Given this list of marker genes DDAH2, PRODH, APBB1, HSPG2, MIR15B, CFDP1, MMP2, MIR133A1, PPP1CA, KCNIP3, UBE2B, CTSH, STAT5A, MAPK8IP2, FCER1G, ELMO2, BRAT1, CECR2, BNIPL, KAT5, ARHGDIA, JAG2, KRAS, AARS1, RBCK1, PTTG1IP, BCL2L14, NAIP, MIR29A, HMGB1, TMIGD1, SCG2, TOPAZ1, PRAMEF17, INS, LIG4, HYOU1, MBTD1, DNMT1, CASP2 (NCBI Gene Id 835), LRP5, CHST11, RNPS1, MRPS30, MIR27A, GATA1, SGK1, PHLDA2, RAPSN, SGK3, ING4, NUPR1, PML, FAM3B, PEG3, PDCD7, WNT11, RPS7, RPS3, SYCP2 (NCBI Gene Id 10388), SLK, G6PD, FZD9, YAP1, DRAM2 (DNA damage regulated autophagy modulator 2), SEMA6A, PLA2R1, CDK11B, HIPK3, TNFSF9, EPO, ALOX12, INPPL1, DLX1, NSG1, TAOK2, KLF4, KCNMA1, RASA1, GRID2, BRMS1, FAP (NCBI Gene Id 2191), SH3RF2, NODAL, STAT5B, RET, BCL11B, ID3, MIR29B1, PAX3, USP17L3, MDM2, IFIT3, ORMDL3, MIR182, CASP12, EYA2 (NCBI Gene Id 2139), DDRGK1, SP100, MAPK9, MAP3K11, ZNF443, SAP18, PRKCI, VDAC2, PRKCZ, MIRLET7F1, CHMP3, HSPD1, TIGAR, DNASE1, CX3CR1, TIAL1 (NCBI Gene Id 8430), VPS72, MYBBP1A, CRYAB, IER3IP1, HLA-G, NR4A3, ZSWIM2, BCL7C, DAXX, TCIRG1, BCL2L13, USP17L21, PAGE4, PDCL3, IL24, WWOX (NCBI Gene Id 9621), GRINA, CDKN1A, CTSB, PDPN, NME3, BABAM2, TXNDC5, AREL1, SOX8 (SRY-box transcription factor 8), RPS3A (ribosomal protein S3A), MIR361, EEF2K, RSL1D1, RARA, NOL3, TNFRSF19, IFT57 (NCBI Gene Id 55081), EP400, NME2 (NME/NM23 nucleoside diphosphate kinase 2), NUAK2, STAT1, ITCH, SEMA3E, CAPN3, NUGGC, ASCL1, SGMS1, SYCE3, DDIAS, BLCAP, WNT7A, ACTN3, RTKN, PTMA, FAIM, IL12B, CARD8, RASSF6, USP53, PPP1R13L, HINT2, IFNB1, TRAIP, THOC6, DNASE1L3 (NCBI Gene Id 1776), TNFAIP8L3, CXCR4, OGT, EBF4, INHBA, DMAP1, GADD45A, NET1, RPS6KB1, SPI1, STK26, PRDX3, PINK1, MERTK, TNFRSF10C, SMAD3 (NCBI Gene Id 51521), MFN2, MAP3K12, LTBR, NME1, PPP2R2B, CORO1A, CHEK2, CHEK1, MAP3K9, TM2D1, USP17L7, RBM5, EGR3, MAP2K5, TNFRSF11B, AGO4, MAPK1, LTF, WNT5A (Wnt family member 5A), UNC5B (NCBI Gene Id 23663), SMO, ATCAY, GRIN2A, TPT1P8, NAE1, PDE1A, RB1, BDKRB2, CEBPB, RNF183, PSMG2, SIN3A, NOG, KPNA1, NCK1, FYN, ING5, NFATC4, ATP13A2, BNIP3, RNF157, AVEN, PTGIS, SON, DNMT3A, GAL, CDCA7, MIR320A, ITGB2, CLEC7A, ARHGEF2, EMP2, CIB1, SHISA5, FGA (NCBI Gene Id 2243), HCK, HSPA1B, TIA1, PRAMEF10, CGB7 (NCBI Gene Id 95511), PAWR, TCF7L2, TNFAIP8L2, GPR65, FGF4, ACIN1, RRP1B, MELK (maternal embryonic leucine zipper kinase), MFSD8, RNF34, STK3, YARS1, STXBP1, CAAP1, SERPINB9, EIF2AK2, NIBAN2, FBH1, CLEC5A, TMEM117, ATOX1, IRF3, BCL10, FRZB, BRAF, DCC, EYA1 (NCBI Gene Id 2138), CDK11A, SOX2, BIK, PRAMEF4, ANGPT1 (NCBI Gene Id 284), CITED2, WNT10B, TFDP1, NCSTN, NEK6, AHI1, CARD11, IFIT2, FGF2, TNFRSF25, SYK, SUDS3, CD160, HRAS, PRKAA2, MAPKAP1, BCAP29, BIRC6, DUSP6, ESR1, BMPR1A, ATN1, TNFRSF1B, MAGEH1, TNFSF11, TRIM2, MNT, TGFB1, ITPKB, PTPA, PPM1K, NFE2L2, LGALS14, HELLS (helicase, lymphoid specific), ATOH1, NES, MAEL, PDE3A, SPG11, CASP8AP2, ERP29 (NCBI Gene Id 10961), IGF1, SAV1, NGFR, FGF10, DAPK2, DNM1L, CCNL1, AATF, CHIA, THOC1, CASP6, SLC39A10, HSPA5, STK40, WNT16, MIR30E, TNFRSF21, PAK2, MYOCD, VEGFA, VIL1 (NCBI Gene Id 7429), VPS54, TFAP2D, C8orf17, DAD1, MAGEA3, PTMS, BBC3, MIR23A, NPC1, CARD6, GADD45B, BIRC3, COMP, TOPORS, AKT1S1 (AKT1 substrate 1), NONO, OLFM1, HSPB2, PRDX5, OXR1, CHL1, ALK, ATAD3A, PCSK9, HSPA1A, CUL1, ELL3, TNFRSF12A, ALDH1A3, SST, TRADD, SH3RF1, EIF5A, LRP8, TNFRSF18, CUL4A, RIPK1, VHL, PPP1R13B, GRK5, DUX4, COA8, ARHGEF6, BCL2L15, PAX2, SPHK2, ATG5, POU4F1, DAPK1, DNASE2, RTL10, MIR138-1, MAP1S, TPT1, MAGEA4, LGALS2, HOXA5, DDX41, PRAMEF1, AIFM2 (AIF family member 2), ARMCX5-GPRASP2, IL4, APAF1, BMP4, FLNA, WNK3, TMEM161A, IL6, CRLF1, PRKD2, IFI6, POU4F2, ANXA2, TLR6, PDIA3 (protein disulfide isomerase family A member 3), JAK3 (Janus kinase 3), SIRT1, CD27, ZMAT3, CRYBA1, TNFRSF1A, EDNRB, PDE6B, YME1L1, PTK2B, HGF, P2RX7, ITGA1, PPARA, HIF1A, CIDEC, GSK3B, TGM2, ACTB, PRAMEF12, SMG9, IL13, VCP, CSRNP3, PIK3CB, HPN, ADARB1, FCGR2B, SIRT5, ACTC1, SOD2, IRF5, SFPQ, EVA1A, PLCG1, USP17L1, EYA3, GZMM, PRAMEF25, CCL3, LAMTOR5, PPARD, RACK1, HSP90AB1, TNFRSF10A, WNT1, NTRK3, CDIP1, RAMP2 (receptor activity modifying protein 2), TRAF4, NDNF, LTA, MNAT1, PRAMEF14, COL2A1, CD14, TSC22D1, NME2P1, NPM1, PHB1, PMAIP1, BMI1, SOX10, BAG6, PRKAA1, BCL2, NR4A1, CXCR2, MIR17HG, VDR, USP17L6P, PLA2G1B, CTLA4, RNF216, STAMBP, TP53BP2, BCL6 (BCL6 transcription repressor), MEF2D, F3, NSMF, VPS35, GRM4, CAST, PRAMEF19, LCN2, CDK5, TIFAB, STEAP3, CRH, ST20, RASSF5, TXNDC12, MFSD10, UNG, NOS1, PRKCH, MAG, TRAF1, GAS6, CD248, MECP2, RB1CC1, FOXC2, ADORA2A, DEPTOR, TMBIM6, NF1, PNMA5, HIP1R, SMAD5, UNC5A, GZMA, EGLN1, ASNS, PPM1F, RAG1, MEAF6, PPP1R10, CARD16, CSRNP2, ARHGEF7, EPG5, XPA, IFNG, MIR222, TARDBP, LPAR1, ST8SIA2, NLRP1, ALPK2, CSNK2A2, ZMYND11, USP17L8 (ubiquitin specific peptidase 17 like family member 8), CASP7, SORT1, ARHGAP10, NEURL1, STX4, PYCR1, MLLT11, SKP2, SOCS2, PTPN6, PLK1, ZEB2, LGALS7B, CD2AP, IKBKE, SPN, BBS10 (NCBI Gene Id 79738), POU3F4, CERS6, LRP6, COL6A2, PTCRA, MIR140, FLT3, KIF14, CASP14, SULF1, CAMK2D, GIMAP8, XKR4, UFM1, PRR5, COLEC11, ZFP36, CD40LG, GADD45G, RELA, ANGPTL4 (angiopoietin like 4), ANP32E, USP17L4, CLIP3 (NCBI Gene Id 25999), CYLD, POU3F3, PRKCD, PARL, MEF2C, SP1, NLRP2B, MIR1-1, DBNDD2, RAPGEF2, IL12A, RAD21, XKR7, COL6A1, IFI27, CEACAM5, CSNK2A1, NRP1, RORC, CIDEB, APP, MIR101-1, MIR675, FOXC1, PF4, SLC25A6, KATNB1, TAF6, TNFAIP8L1, PPP2CB, IL10, GULP1, APLP1, PAK6, SH3GLB1, FOXP1, ANO6, LYN, UBE2D3, ACTN4, ADIPOQ, DELE1, MIR15A, TP73, RPL10, PPT1, SH3KBP1, MIR142, LIMS2, PRKCE, FCHSD1, FOXO1, ELP6, SERPINE1, ITGB1, PIP5KL1, EBAG9, SNX6, SPDEF, SLFN12, HTT, DFFA, CBL, ABCC9, PTGS2, RYBP, CDKN2D, FIS1, CLU, BRCA2, MIF, PARP2, PKN1, GLS2, FBXO11, LYPD3, SCRIB, FBXO21, PLK2, DDX47, EMILIN2, CCL2, CAV1, ATF3, AGTR2, TMEM238L, TENT5B, TRAF3IP2, PRAP1, EPB41L3, CUL5, TJP1, CDK19, MIR221, PRDM11, ZC3H12A, GNGT1, MIR181B1, SEMA5A, INCA1, GPER1, SNW1, PAK5, ALOX15B (arachidonate 15-lipoxygenase type B), CITED1, TAX1BP1, IL11, SLIT2, E2F2, TNFSF14, AIFM1, DPP8, ARF6, MIR210, GRN (granulin precursor), FASTK (Fas activated serine/threonine kinase), ERBB4, UXT, RNF186, TFAP4, FAIM2, LONRF2, ZNF212 (zinc finger protein 212), ANGPT4, CCAR2, CAPN2, PFKFB3, RPS27L, DNM2, MTDH, MIR132, E2F1, FGF20, BACE1, RPS6, MED1, EGLN2, TMEM196, FANK1, SCN2A, BID, MYB, ERCC5, PDCD4, SOD1, KRT20, PRAMEF9, NR4A2, EMP1, CBX4, KCNJ8, BAD, MAPK8IP1, PA2G4, GGCT, GCLM, PDCD2L, CAPN10, SCRT2, GATA5, IFI27L1, TNIP2, ADAM8, SERPINB13, CCND2, DDR2, SFRP4, ERFE, UBQLN1, ATF6, HEY2, TSC22D3, SRA1, NME5, DAPK3, ANP32CP, CDC73, NHERF1, SEMA4D, HTR2A, ERCC6, MIR21, EN2, EIF2S1, P2RX1, PIM1, DDB1, NTRK2, MLST8, TNFSF15, MRPL41, APBB2, BCL2A1, LTK, SOCS3, METTL21C, TRAF7, TUBA1A, PALB2, GSTP1, PRR7, FEM1B, GOLPH3, ADAR, MRGBP, ADNP, STUB1, DAP3, NCK2, B4GALT1, TLR3, PIAS1 (protein inhibitor of activated STAT 1), DAB2, SCX, API5, ATP2A2, RNF130 (NCBI Gene Id 55819), SIX4, USP17L2, GLI3, AHR, UNC13B, BARD1, PACS2, MAPK3, MMP9, RPS6KA1, MCM2, IRF7, SHC1, TPX2, CCNL2, ZC3H8, HSP90AA1, PPIA, PAX8, NANOS3, FATE1, EEF1E1, PTEN, ZPR1, TCIM, QARS1, BLOC1S2, HIF3A, CIT, ATP5IF1, ISL1, ITGB3BP, PEA15, SUPV3L1, ZBTB7A, FBXO10, ERCC3, IL1A, ADCY10, ST3GAL1, PDPK1, C1QBP, CD274, LAPTM5, HTRA1, S100A8, SLC9A1, DUSP1, DIDO1, MIR495, DIPK2A, XKR9, EPC1, MNDA, ADRA1A, TERT, TNFSF18, LGALS3, PYCARD (PYD and CARD domain containing), TLE5, OPA1, EEF1A2, THEM4, STK24, IGFBP3, MTFP1, BIRC7, PCDHGC5, MAP2K7, ARL6IP5, NPR2, FAS, AXIN1, MIR98, ITGA5, BNIP2, ATG4D (autophagy related 4D cysteine peptidase), PTGFR, ANXA1, EGFR, LGALS12, IFNA2, USP17L11, EPC2, GPI, USP27X, CEACAM6, UNC5C, FAF1, MAP2K1, C1D, CCR5, APC, MIR375, SGPL1, KCNQ3, KRT8, TMC8, GRIK2, RALB, TP53AIP1, MIR186, NPY5R, RBM25, TBX1, HDAC2, STK4, DKK1, THRA, CD2, CD44, FFAR4, MEF2A, HNF1B, CNTFR, FRS2, CYP1B1, HINT1, DKKL1, PMP22, CTNNBL1, PERP, FZD5, KDM2B, MCL1, PRAMEF27, DPF1, SNCB, IL6R, DHRS2, NCKAP1L, MAP2K6, TNFAIP3, EXOG, PRAMEF33 (NCBI Gene Id 645399), MINAR2, CRIP1, NKX2-5, ARAF, AIFM3, DLG5, MIR30B, FZD1, BUB1, VTCN1, DNASE2B, IL17A, CXCL10, MINDY3 (NCBI Gene Id 80013), IGF2R, NOTCH1, BLID, XKR6, RYR2, GFRAL, MPV17L, TNFSF10, TLE1, NOD1, ITGA4, GBE1, CHI3L1, EDA2R, TMBIM1, FHL2 (four and a half LIM domains 2), PHLPP1, ACSL5, APEX1, ITGAV, USP28, PPARG, DLC1, AKTIP (AKT interacting protein), RAF1, PPP2R1B, ACTN2, TGFB2 (NCBI Gene Id 7042), LCK, PCGF2, SHC4, RNF41, BMPR1B, UTP11, EIF2AK3 (eukaryotic translation initiation factor 2 alpha kinase 3), NR1H4, CCR7, AURKB, NAIF1, BTG2, SMAD6, BCL2L1 (NCBI Gene Id 598), TMEM219, MIR20A, TMEM14A, CDK5R1, CASP1, BMP5, G2E3, ARMC10 (NCBI Gene Id 83787), PIK3CD, SHB, NUDT2, JADE1, EI24, HTATIP2, MX1, ROBO2, FCMR, MGMT, MAPK7, SNCA, UBD, ARG2, RGL2, CCL5, ACVR1C, IL20RA (interleukin 20 receptor subunit alpha), LOX, ENSG00000274276, AFP, ANXA4, BCLAF1, SRGN, ATP2A1, GZMH, ZFP36L1, C8orf44-SGK3, CREB3L1, HTR2B, AAMDC, SPHK1, HDAC1, BAG1, BEX2, HDAC3, E2F3, USP17L12 (NCBI Gene Id 100287205), BMX, CALR, GZMB, PRELID1, NFKBIZ, CFLAR (CASP8 and FADD like apoptosis regulator), MITF, RGCC, MTOR, DYRK2, ALX4, SELENOS, HTRA4, SFRP5 (secreted frizzled related protein 5), ADAM17, MSH2, CERKL, GLO1, BRD8, MALT1, MAP4K4, LMNA, FBXO7 (NCBI Gene Id 25793), LEP, HMOX1, COL6A3, NOC2L, LGALS13, ITGB3, STK17A, UCN, PAK4, DOCK1, IL19, F2R, SLC5A11, SDF2L1, ERBB3, TGFBR1, TNFRSF8, USP15, SHF, TMEM258, NOX1, LRP2, NKX2-6, MIR17, APOE, EYA4, BARHL1, INTS1, CCL19, HIPK1 (NCBI Gene Id 23323), MSX1, PIK3R3, CXCL12, NOD2, P2RX4, RELT, RBM14, FADD, HIGD2A, TNFAIP8, VSTM2L, TICAM1, IVNS1ABP, PDCD10, PARK7, PAX7, ANKRD13C, GNAI2, C19orf12, ARL6IP1, BIRC5, PRDX2, ERRFI1, CLN8, INPP5D, KDM1A, MIR199A1, PLK3, TMEM214, MLH1, TRIM24, CASP10, PDCD2 (NCBI Gene Id 5134), NLRP3, FGFR3, SHH, PLEKHF1, HRG, ELMO3, NNT (NCBI Gene Id 23530), BIRC2, TNFAIP1 (TNF alpha induced protein 1), KLF11, HMGA2, SLC5A8, MIR28, PTK2, BUB1B, NAT8B, ING2, CDH5 (NCBI Gene Id 1003), MADD, MAGED1, CTSD, PLAUR, GHRL, TFPT, DDIT4, USP17L18, NFKB1, ANXA6, NOX5, GSK3A, LMBR1L, CNTF, LHX4, MIR204, ADORA1, FXN, ATF4, IRF1, CTNNB1, APIP, MIEN1, FXR1, IKBKG, AGT, RARB, NF2, MEGF10, CGB3, UACA, NKX3-2, CTSC, ALX3, IFI27L2, TBX20, CBLC, FBXW7, AKT2, SLC1A1, GAS2 (NCBI Gene Id 2620), SIRT4, ERN2, STIL, CKAP2, NHLH2, SLC27A4, CD38, FMR1-AS1, ELMO1, CYCS, DSG2, FMC1, XRCC4, CCN1, TEX11 (testis expressed 11), DBH, MIR19A, BTC (NCBI Gene Id 685), PPID, DNAJC5, TMTC4, MARCHF7, DICER1, ETV6, TNFRSF10B, GSDME, TRAF6, TAF9, PLEKHN1, FGFR1, SLC40A1, FOSL2, ERO1A, KHDC3L, NPTX1, MIR24-1, EMC4, NTRK1, SOX9, TIMP1, HTRA2, FGFR2, IL7, CFL1, ZBTB16, EDNRA, PSMD10, BMP7, MIR200B, PEG10, FAM32A, ASIC2, CUL2, SLIT3, PRAMEF20, KNG1, POR, DEDD2, PIGT, DNAJA1, MIR590, EVI2B, THBS1, MAL, LRRK2, PPP1R15A, NISCH, KHDRBS1 (NCBI Gene Id 10657), LACRT, SMPD1, SOX4, BRSK2, CHAC1, SNAI2, MYC, TGFBR2, AKAP1, KLHL20, CRADD, ABL1, RHOB, BAG3, NOP53, VDAC1, ENO1, S100A14, AKR1A1, ERCC2, SFN, ITPRIP, ANG, MIR212, SMNDC1, PDK4 (NCBI Gene Id 5166), CAT, ROCK1 (NCBI Gene Id 6093), BAP1, MTCH2, SRC (NCBI Gene Id 6714), RNF122, SLC25A4, MAGI3, PIDD1, RIPK3, GATA2, NOTCH2, BDNF, GPX1, HOXA13, PLAGL1, LCMT1, ING3, DIO3, MPO, MYDGF, CDK1, DRAXIN, PIK3CA, MAZ, NR3C1 (NCBI Gene Id 389335), HYAL2, RRN3, ZNF304, CASP5, TOX3, PRKCB, FLT4, PRAMEF7, ANP32A, BNIP1, AEN (NCBI Gene Id 64782), BAK1, HAX1, GRAMD4, PRAMEF6, ATM, AR, MIR19B1, TAOK1, PELI3, PHIP, HSPE1, FGB, IL7R, ADA, POU4F3, PRKCQ, QRICH1, RFFL, BIRC8, PLAGL2, IL1B, TLR2, STPG1, LTB, MIR106B, BCL7B, PPP5C, ACVR1B, ARSG, CTH (cystathionine gamma-lyase), CAMK2A, RPS6KA3 (NCBI Gene Id 6197), AXL, MIR26B, AGAP2, HIC1, CASP8, CAMK1D, FOXE3, EP300, CPEB4, MZB1, MDK, PPP2R5C, BTG1, ZNF622, AHCYL1, JUN, CASP4, MIR27B, ITM2C, BCAP31, FIGNL1, GABARAP, EGR1, SERPINB2, HCAR2, CIAPIN1, AKR1C3, MAP2K4, NBN, RASSF2, CCAR1, AIMP2, SNAI1, LGALS9, KANK2, TOMM70, RNF144B, ARNT2, URI1, AMBRA1, RMDN3, RIPK2, ECT2, ACVR1, UBE2Z, PPIF, BAX, RRM2B, STK17B, XBP1, MIR125A, PDCD5, USP17L15, ATAD5, TRIB3, CXCR3, PLSCR3, PROC, TXNIP, BCL3, DYRK3, GSN, ZMPSTE24, DAP, BFAR, GRIA4, RRAGC, PIM2, BAG5, AZU1, DDX5, MTCH1, PRAMEF13, PAEP, WNT4, ALDH1A2, ANKRD1, EPHA4, NDP, CTNNA1, CD70, MIR146A, TSLP, BNIP3L, MIR126, FMN2, ATF2 (NCBI Gene Id 1386), PPP2R1A, SPIN2B, SLC25A31, SLC35F6 (NCBI Gene Id 54978), NLRP2, MYCNOS, PCDHGC4, CLCF1, RBM10, FGG, MAP3K10, KRT18, CCND1, RHOT2, SPTLC1, CLN3, MIR29C (NCBI Gene Id 407026), RHBDD1, XIAP, ZDHHC3, GML, DSTYK, ZBP1, PRAMEF11, BCL2L2, HK2, MSX2, IRS2, RFK (riboflavin kinase), UMODL1, LEF1, TNFRSF6B, ZNF268, ERN1, HCLS1, GPLD1, MT3, CBS, ITPR1, FZD3, ATP2A3, SFRP2, FNIP2, RPL26, PRF1, NEFL (NCBI Gene Id 4747), SIAH1, EN1, TEX261, OPN3, KITLG, NRG1, ERBB2, EGLN3 (egl-9 family hypoxia inducible factor 3), TBX3, MTNR1B, PHLDA1, THAP11, DNAAF10, S100A9, YBX3, PHB2, CRKL, IHH, ALKBH1, IL31RA, GDF5, GATA3, ACTL6A, ZNF205, TFAP2A, PRLR, EFNA1, DCUN1D3, IFT80, FASTKD2, IL2RA, ICAM1, DYNLL1, ZFAND6, BCL2L12, PRICKLE1, AIMP1, NLRC4, PTPRC (NCBI Gene Id 5788), GAS1, PIK3CG, PTPN1, TSPO, HYPK, KIFAP3, XAF1, HSF1, ADAMTSL4, UCP2, TEK, NOS3 (nitric oxide synthase 3), NCOA1, TRIM35, SLTM, RTN4, SIX3, CLPTM1L, PAK1, USP47, MIR145, DOCK8, ATF5, SIX1, FUT1 (fucosyltransferase 1 (H blood group)), GREM1, UBE4B, SHARPIN, CARD18, DDIT3, PRKD1, TMF1, GDF6, MECOM, PDK1, MIR449A, ATP7A, KRIT1, P4HB, FOXO3, G0S2, EIF2B5, ANKLE2, C6orf120, TRAF3, GDNF, RETREG1, TREM2, SCIN, TBX2, SIVA1, GBA1, NTF4, ECSCR, CX3CL1, CARD17P, ADAMTS20, PIP, LGALS16, RRP8, PPARGC1A, WT1, ZNF16, ZNF830, SSTR3, ZNF385A, OMA1, FCAR, PLEKHO2, MYD88, TLR4, TFRC, HS1BP3, FPR2, USP42, MUC1, USP17L17 (NCBI Gene Id 124906407), CDK5RAP3, DDX3X, PNMA3, LALBA, TNFRSF9, HERPUD1, USP36, TRRAP, S100B, RARG, MICAL1, RUVBL2, ADAM15, FSTL1, TNF, NTSR1, PTPRZ1, SIRT2, DAPL1, PITX3, NAA16, IL2RB, PPEF2, MAPK8IP3, BMP2, MIR200A, HAND2, TRIM69, HNRNPK, PRMT2, MORF4L2, PTPN2, DYNAP, JTB, USP17L20, HRK, WFS1, PRDM9, NRBP2, TRIM39, NACC2, PLA2G3, AVP, NCKAP1, PKHD1 (NCBI Gene Id 5314), TCHP, GNRH1, KREMEN1, CADM1, EDAR, PROK2, TIMM50 (translocase of inner mitochondrial membrane 50), CSF1R, ATG7, PIAS4, MUL1, HSPB6, VEGFB, SGPP1, MAP3K20, TAF10, SFRP1, PTRH2, PSEN1, KLLN, EMILIN1, ENDOG, TRPC5, SPRY2, UNC5D, KCNJ11, TP63, MORF4L1, INHBB, MIR34A, BCL2L10, RTKN2, PLXND1, TRIAP1, IGF1R, AKR1B1, ITGA6, CIDEA, CCL21, CSRNP1, GMPPA, SELENOK, PNMA1, FNIP1, RRAGA, SLC46A2, ACTN1, ZNF385B, CARD14, RASSF7, MSH6, ANXA5, GAPDH, PRAMEF8, NUP62, NKX3-1, LGMN, MARCKS, TP53BP1, AURKA, VNN1, APOH, ATG3, RUVBL1, SRPX, IKZF3, MRE11 (MRE11 homolog, double strand break repair nuclease), PRKN, DNAJC3, MKNK2 (NCBI Gene Id 2872), PCGEM1, NGF, MOAP1, CDKN2A, PROP1, GSKIP, TAF9B, PDCD6, STK11, KDELR1, FHIT, TNFSF12, RAD9A (RAD9 checkpoint clamp component A), BMPR2, RPS6KA2, C3orf38, STYXL1, YEATS4, MAEA, ACKR3, GCG, LIPA, DNAJC10, UMOD, PDCD1, NR2E1, PANO1, TRAF5, TNFRSF10D, ELK1, HIGD1A, PIM3, CARM1, PRKDC, PTH, DIABLO, CARD9, FKBP8, MIR4516, PARP1, NAA38, OSR1, GHSR, GPX4, XRCC2 (X-ray repair cross complementing 2), MIR181C, TMEM109, DDX42, EXOC5, IER3, MIR16-1 (NCBI Gene Id 406950), LATS2, USP17L19, HIPK2, TMEM102, PIK3R1, CHCHD10, DPF2 (double PHD fingers 2), USP17L13, NMNAT1, CD5L, GHITM, CLC, HSPA9, GLRX2, SMAD4, SERINC3, ACAA2, MAPK8, FOXL2, TMBIM4, KCNB1, PHLDA3, TRAP1, CD3E, IL27RA, MYO18A, CD40, PLK5, PRAMEF26, JAK2, PRKRA, ANP32B, PTPRH, CREB3, USP17L24, BIN1, TCTN3, LHX3, FLCN, PUF60, STK25, POLB, CTTN, TFAP2B, ENG, ASAH2, DNAJA3, KMT2A, SET, CTSL, CHD8, SLC25A27, DFFB, IP6K2, MAP3K5, PTPMT1, PLAC8, CD47, HPGD, GCLC, ZDHHC16 (zinc finger DHHC-type palmitoyltransferase 16), CRYAA, RXFP2, SRSF6, MAPK14, PRAMEF15, IRF8, SLC25A5, CD28, BMF, TRAF2, AKT1, KDR, BRCA1, SRPK2, GATA6, GATA4, PDCD6IP, HIP1, NOA1, GPRASP3, FOXB1, IDO1, FGF8, TGFB3, USP17L5, SLC7A11, ID1, PDX1, BECN1, CRIPTO, TWIST1, UBB, GALNT3, CUL3, MIR451A, MIR137, NPPC, EPHA7, ARF4, PRAMEF18, CDKN1B, HMGN5, SEPTIN4, NDUFA13, AIPL1, USP17L22, IL2, SKIL, RHOT1, SARM1, RICTOR, TRIM32, CYFIP2, PRAMEF22, BBLN, SYVN1, CD5, CASP9, ESPL1, ETS1, PCDHGC3, HSP90B1, DRAM1, FOXA1, BAG4, LILRB1, USP17L10, EFNA5, CARD10, IFI16, KIF1B, EMP3, CASP3, CSF2 (NCBI Gene Id 1437), HMGB2, NACA, PRAMEF2, SLC7A5, EDN1, PSME3, DMPK, LGALS1, DLL1, PRKCA, TPD52L1, GPAM, TYRO3, NEUROD1, PDK2, IL33, YWHAZ, CALHM2, LATS1, BOK, AKAP12, STRADB, ACER2, CD3G (CD3 gamma subunit of T-cell receptor complex), PRKCG, AQP1, IL6ST, SIK1, PRUNE2, CD74, AATK, DEDD, MIRLET7B, RHOA, IAPP, BCL2L11, SYNGAP1, BTK, BCAR1, NAA15, NTF3, RNF152, COPS5, RTN3, MIR92A1, EAF2, NME6, PRAME, HSPB1, EPHA2, DDX19A, NTN1, MIR195, PRAMEF5, FASLG, NAA35 (N-alpha-acetyltransferase 35, NatC auxiliary subunit), CD24, JMY, PRNP (prion protein (Kanno blood group)), THRB, TP53INP1, SQSTM1, BEX3, PNMA2, XKR8, HSH2D, RABEP1, TP53, COL4A3, MAP3K7, SIAH2, DAB2IP, FAM162A, PKN2, MDM4, DDX20, PLSCR1, TSC2, TOP2A, SIGMAR1, CREB1, here is a description of the gene set: studied in species Homo sapiens A programmed cell death process which begins when a cell receives an internal (e.g. DNA damage) or external signal (e.g. an extracellular death ligand), and proceeds through a series of biochemical events (signaling pathway phase) which trigger an execution phase. The execution phase is the last step of an apoptotic process, and is typically characterized by rounding-up of the cell, retraction of pseudopodes, reduction of cellular volume (pyknosis), chromatin condensation, nuclear fragmentation (karyorrhexis), plasma membrane blebbing and fragmentation of the cell into apoptotic bodies. When the execution phase is completed, the cell has died. Human Gene Set: GOBP_APOPTOTIC_PROCESS